Given this list of marker genes SERINC3, SERINC5, PSPH, PHGDH, SHMT2, PSAT1, here is a description of the gene set: Human Gene Set: GOBP_L_SERINE_BIOSYNTHETIC_PROCESS studied in species Homo sapiens The chemical reactions and pathways resulting in the formation of L-serine, the L-enantiomer of serine, i.e. (2S)-2-amino-3-hydroxypropanoic acid.